The following is a description of a gene set: Reactome Pathway: Immune System This event has been computationally inferred from an event that has been demonstrated in another species.<p>The inference is based on the homology mapping from PANTHER. Briefly, reactions for which all involved PhysicalEntities (in input, output and catalyst) have a mapped orthologue/paralogue (for complexes at least 75% of components must have a mapping) are inferred to the other species. electronically inferred by orthology from the curated human pathway species: Mus musculus, and this is the list of marker genes: H2ac20, Dad1, Wsb1, H2-Q7, Trim32 (NCBI Gene Id 69807), Ifitm2, Crk, Cst3, Gan, Tnf, Mvp, Trim56, Ltb, Trim36, Ap2s1, Ifna16, Prkn, Defa36, Ly86, Pdzd11, C1ra (NCBI Gene Id 50909), Clcf1, Pag1, Tusc3, Ap1b1, Inppl1, H4c3, Nme2, Tlr6, Il16, Npm1, Atp6v0d1 (NCBI Gene Id 11972), Gpr84, Fcer1a, Fbxl8, C9, Pdap1, H2ac8, Mapk7, H2-M10.1, Faf2, Tlr1, Ezh2, Fbxo27, Neu1, Defb18, Traf3, Enpp4, Klrc2, H2ac4 (H2A clustered histone 4), Tab2 (NCBI Gene Id 68652), Nckipsd, Ulbp1, Ptk2, Asb16, Mapk8, Atp6v0a4, Il12b, Ptges2, Cdc23, Casp1, Galns, Actr2 (NCBI Gene Id 66713), H2-M9, Copb1, Lpo, Tubal3, Kifap3, Fbxl19, Pdcd1, Fkbp1a, Nf2, H3c15, Colec11, Itgax, Pianp, Rnf217, Rbsn, Il6, Leap2, Cd70, Lta, Crispld2, Rnf7, Eif4a1, Cd14, Tubb4b, Prkacb, Ppp2r5d, Smurf1, Cpped1, Nkiras1, Pik3c3, Ubac1, Sumo1, Gbp2, Casp9, Ear6, Atp6v1a, H2ac23, Ube3b, Lif, Sugt1 (SGT1, suppressor of G2 allele of SKP1 (S. cerevisiae)), Pja1, Kctd7, Tlr4, Serpinb3a, Defa39, Psg22, Vcp, Lonrf1, Tnfsf12 (tumor necrosis factor (ligand) superfamily, member 12), Chit1, Trim50, Psmd7, Ptpn2, Prkag3, Ap2b1, Rnf19a, Ormdl3, Ifngr2, Pdpk1 (3-phosphoinositide dependent protein kinase 1), Ppp2r5b, Aim2, Stt3a (STT3, subunit of the oligosaccharyltransferase complex, homolog A (S. cerevisiae)), Orm2, Csf1r, Ptpn6, Dync1li2, Pla2g2a, Fancc, Ear2, H2az2, Cdk13, Bpifa1, Defb19, Rnf6, Hcst, Tmem63a, Ube2e2, Ifna12, Lgmn, Faap100, Irak3, Fyn, Try10, Cmtm6, Bpifb6, C5ar1, Il6ra, Plau, Ifnl3, Il33, Defa30, Tnfrsf1a, Erap1, Smarca4, Asb17, Eppin, Rasgrp1, Sec24a, Tifa, Tlr8, Kctd6, Ifna14, Cct8, Socs2 (NCBI Gene Id 216233), Tuba1b, Defa20, Cfi, Frmpd3, Rab3a, Cntfr, Ube2g1, Cd209a, Oscar, Tab3, Ap1s1, Cdc34, Itga4, Cenpe, Lag3, 1600012H06Rik, Hp, C1qc, Il2, Dnase1l1, Psma7, Mmp8, Ifi205, Eef1a1, B3gnt3, Gdi2, Psmc3, Eda, H2-M2, Vtn, Svs3b, Cxcl1, Cenps, Actr10, Lamtor1, Arih1, Ufl1, Det1, Card9, Defa42, Psma5, Thop1, Nlrp3, H2-Ob (NCBI Gene Id 15002), Asb18, Psmb10, Ctsh, Cd81, Fabp5, Clec4a3, Fpr1, Klrk1 (killer cell lectin-like receptor subfamily K, member 1), Ppp2r5a, Itgb5, Il2rb, Slpi, Defb3, Ms4a2, H2bc22, Vps35l, Osbpl1a, Fgr, Il13ra1, Gbp5, Map2k4, Rasgrp3, S100b, Ifitm3, Mapk9, Tnfrsf18, Panx1, Sdc1, Ifi30, Atp6v1f, Grap2, Vat1, Ceacam2, Klkb1, Npc2, Csf2rb, Prkag1, Rbbp4, Psma1, Kpnb1, Fnta, H3f3a, Cd300ld4, Tubb6 (tubulin, beta 6 class V), Dctn1, Treml2, Tnfrsf17, Trem2, Ddost, Bcl2l1, Vhl, Sec24d, Cep290, Map2k3, Ear10, Adgre5, Nfam1, Btn1a1, Atp8a1, Tubb4a, Prg2, Kif5b, Cd55, H2-M10.6, Siglec1, Raet1e, Tmem30a, Itgb7, Cd300e (NCBI Gene Id 217306), Mapk12, Rab18, Orm1, Tnfrsf1b, Slc44a2, Il36a, Mib2, C1qa, Crlf1, Pgm2, Bpi, Tnfaip3, Grn, Herc3, Slc2a5, Dock2, Kif2c, Prg3, Dctn6, Vapa, Psma3, Tnfrsf13c, Nfkb1, Cd27, Casp3, Ifng, Irag2, Faap20, Cpn2, Ccnf, Atp6ap2, Rnf111, Prss2, Ppp3r1, Calr, Arhgap9, Cda, Ncf1, Il4, Sla, Socs3, Atp6v1e2, Ctsc, Kcmf1, H2ac22, Dtx4, Defa21, Anapc2, Casp8, Pglyrp3, Uba5 (NCBI Gene Id 66663, ubiquitin-like modifier activating enzyme 5), C4b, Hvcn1, Cd3g, Serpinb3c, Pld2, Hsp90b1, Defb25, Il9r, Ube2k, Ifna15, Asb5 (NCBI Gene Id 76294), Fzr1, C8a, Cdc42, Il1f10, Rchy1, Fbxl5, Mapk14, Fbxl15, Rela, Tyk2, Tnfsf15, Tirap, Jak3, Cul1 (cullin 1), Spop, Arpc4, Actr1a, Ube3d, Atp6v0c, Asb8, Gstp1, Reg3d, Pja2, Lcp2, Malt1, Slc11a1, Psma2, Adgrg3, Olfm4, Stim1, Tnfsf13, Nlrp4c, Pycard, Icam2 (NCBI Gene Id 15896), Defa17, Fancb, Cul7, Jup, Ctsf, Tlr2, Rictor, Fbxw4, Ceacam1, Il22 (interleukin 22), Erlec1, Kng2, Csnk2b, Tlr7, Ifna4, C5ar2, Lmo7, Il11, Tasl, Stk10, Fcna, Tnfsf14, Gsdmd, C3, Asb14, Ifna1, Ifnl2, Ube3c, Atp6v0e2, Arih2, Reg3g, Cd226, Siglecg, Sting1, Ampd3, Defa32, Fbxo9, Map3k3 (mitogen-activated protein kinase kinase kinase 3), C6, Mapk11, Rnf144b, Unc13d, Mapt, Flt3l, Arpc5, Vnn1, Lnx1, Cd28, H3c7, Ifngr1, Rbbp7, Klc4, Tnfrsf25, H4c12, Rab37, Ap1m1, Ifnlr1, Defb14, H4c6, Lamtor2, Trim69, Pstpip1, Defb21, Nos2, Glipr1, Ear1, H3c4, Il1rl1, Il1r2, Cant1, Psmd13, Irs2, Camk2b, Psmc5, Hexb, Tuba1a, Rnase6, Fbxl21, Ube2n, Treml1, Pde12, Trim11, Klrc1, Ahsg, Adam8, Tlr9, Pld3, Il2ra, Fbxo10, Rnf123, Cd36, Dok3, Arg1, Snca, Ilf2, Acaa1b, Cd3e, Rnase2a, Cpn1, Casp2 (NCBI Gene Id 12366), Gh, Cd68, Defa23 (defensin, alpha, 23), Il27ra, Masp1, Colec10, Lta4h, P4hb, Reg3b, Fbxo17, Eif4e3, Ifi211, Atp6v1g3, Ep300, Il21, F12, Ifnab, Stat5a, Irak1, Armc8, Hecw2 (NCBI Gene Id 329152), Pilra, Mmp25, Cd300ld5 (NCBI Gene Id 100043125), Slco4c1, Lrrc14, Rap2c, Tarbp2, F2, Tuba8, Lrr1, Pnp, Ccr6, Fgl2, Il20ra, Hrg, Tuba3b, H2-M10.2, H3c13, Dsg1a, Dusp7, Rac2, Ubb, Hebp2, Il36b, H2ac24, Igf2r, Rps27a, Ube2r2 (ubiquitin-conjugating enzyme E2R 2), Sec31a, Nlrx1, Fancg, Brwd1, H2ac10, Erp44, Tuba4a, Ticam2, Slamf7, Xrcc6, Siglece, Relb, Pik3ap1 (phosphoinositide-3-kinase adaptor protein 1), Masp2, H2-Oa, Btn2a2, Cnn2, Tyrobp, Defa34, Sftpd, Psme1, Fbxl16, Snap29, Ap1s3, Ckap4, Traip, Trem1, Sqstm1, Defa31 (NCBI Gene Id 13226), H2bc12, Asb12, Smurf2, H2bc13, Ppia, Arf1, Clec4n, Uba1 (ubiquitin-like modifier activating enzyme 1), Psen1, Cd300ld3, Il2rg, Il18rap, Tnfsf8, Optn, Defb48, Dynll1, Capn1, Cfp, Them4, Calm1, Arsa, Il34, Ms4a3, Shc1, Rnf213, H4c2, Il1a, Map3k8, Vrk3, Ctla4, Spsb2, Dynlt1a, Cd80, Lilra5, Prcp, Ost4, Col17a1, Fbxo30, Cotl1, Map2k7, Bri3, Nhlrc3, Igll1, Tnfrsf11b, Stx3, Tcirg1, Fbxo32, Bpifa2, Kif2b, Rigi, Rnaset2a, Mefv, Cd3d (CD3 antigen, delta polypeptide), Ube2s, Lbp, Btnl9, C1s2, C1qb (NCBI Gene Id 12260), Il10ra, Impdh2, Il11ra1, Il31, Trat1, Clec4d, Yes1, Defb42, Vamp8, Reg3a, Mapk13, Defa3, H2-M3, H4c9, Cntf, Jaml, Tnfrsf11a, Defa25, Rab7, Ilf3, Cyld, Klhl41, Ube2w, Psma6, Defb43, Defa26, H2bc7, B2m, Socs1, Lck, Defb36, Tnfrsf14, Nectin2, Defa37, Cyba, Psmb9, Ifna9, Ghdc, H2bc11, H3c10, Irf3, Asb9, Psmd6, Arel1, Mrc2, Defa38, Cd8b1, Defb1, Bpifb4, Ube2d1, Unc93b1, 2310033P09Rik, Tnfrsf4, Creg1, Ifitm1, Ppp2r1b, Anapc7, Hspa1l, Dnm2, Cbll1, Mavs, Ctsd, Fos, Siglecf, Il1r1, Slc27a2, Crtam, H3c1, Il18r1, Tap1, Rab9b, Crisp2, Serpinb3b, Il19, Atg7, Sos2, Tab1, Atp6v0e, Vav1, Wasf3, Mapk3, Lamp2 (NCBI Gene Id 16784), Kif20a (NCBI Gene Id 19348), Itgal, Cdc26, H3c3, Arl8a, Osmr, Trim39, Cd79a, H2ac19, Eif4a2, H2ac6, Pak3, Il27, Itk, Il9, Ctss, Nfkb2, Icos, Tec, Man2b1, Sh3glb2, Prdx4, Peli2, Il23r, Btbd1, Dapp1, Actr3, Anxa2, Icam4, Eef2, Cd177, Atp6v1d, Cstb, Psap, Kif26a, Ccnd1, Prkaca, Becn1, Rnf126, Rnf4, H3c11, Csk, Racgap1, Pik3r2, Cd300ld, H4c4, Oasl1 (2'-5' oligoadenylate synthetase-like 1, NCBI Gene Id 231655), Pnp2, Defb28, Tnfsf11, Anpep, P2rx7, H2ac1, Nlrc5, Cfd (complement factor D), Syk (spleen tyrosine kinase), Mcemp1, Alad, Defa28, Cd46, Gsn (gelsolin), H2bc8, Ppl, Rnf182, Fbxo31, Cyfip2, H3c8, Mre11a, A2m, Naprt, Mospd2, Pglyrp4, Il5, Fbxl14, Kpna1, Il31ra, Cd200r2, Il15, Osm, Il21r, Dtx3l, Itgb2, Defa43, H3c6 (NCBI Gene Id 319151), Il10, Pa2g4, Cdkn1b, Sec24b, Tmem258, Derl1, Clec4b2, Klhl13, Aldh3b1, Atp6v1g2, Rab10, Elane, H2-Q10, Psmb6, Cbl, Hmgb1, Hspa2, Chga, Kbtbd8, C8g, Defa24, H2bc1, Cd300lb, Psme2, Il20, Il3, Gzmm, Clec12a, Plaur, Trpc1, Kbtbd13, Ptprc (NCBI Gene Id 19264), Cct2, Arpc2, H2ac7, Cracr2a, H4c14, Ecsit, Mbl2, Ppm1b, Irf7, Pla2g6, H2bc15, Siah1a, Klrc3, Psmb5, Serping1, Dcaf1 (NCBI Gene Id 321006), H2bc9, Icosl, Il18bp, Psmc6, Defa41, Birc3, Fbxl4, H2bc27, Fbxl7, Irf9, Cxcr2, Il5ra, Nfkbie, Anapc10, Qpct, Clec4a4, Clec4g, Cd207, Pglyrp1, Klrb1a, H2ac12, H2ax, Ctsg, Mif, Defa35, Sptbn2, Stat4, H3c2, Hk3, Psg29, Dus2, Camp (cathelicidin antimicrobial peptide), Cd19, Myd88, Tubb2b, Apeh, Csf2, Klhl5, Tnfaip6, Kif3c, Kcnab2, Cd79b, Lat, Cxcr1, Clec4b1, Stx4a, Sh2b3, Anapc13, Pkm, Aldoa, Cr1l, Irf5, H2ac15, Hras, Fbxo40, Rab6a (NCBI Gene Id 19346), Ap2m1, Blnk, Rab5c, Svip, Fbxl3, Il4ra (interleukin 4 receptor, alpha), Sdcbp, Fance, Hectd3, Ncf2, Cdk4, C3ar1, Atp6v0a1, Txn1 (NCBI Gene Id 22166), H2ac11, C2, H4c18, Cystm1, Irs1, Ube2o (ubiquitin-conjugating enzyme E2O), Tspan14, Klrd1, Cd96, Epx, Rab44, Defb47, Dynlt1b, Dusp6, Ist1, Asb10, Rnase2b, Ifnar1, Xdh (NCBI Gene Id 22436), H2ac13, Hmox2, Cdk1, Ddx41, Tuba1c, Sel1l, Pik3cb, Psmb8, Tnfsf9, Unkl, Prtn3, Pigr, Ap2a1, Ifi204, Tnfsf18, Grb2, Cblb, Ube2c, Uba7, Ube2v1, Tap2 (transporter 2, ATP-binding cassette, sub-family B (MDR/TAP)), Hc, Tom1, Nfkbib, Glmn, Cenpx, Ptpn22, Clec4a2, Psmb4, H2bc3 (H2B clustered histone 3), Psmd1, H4c11, Trp53, Map3k14, Hectd2, Vamp2 (NCBI Gene Id 22318), Stx1a, Cd40lg, Hbb-bt, Il13ra2, Casp4, Flnb, Il23a, Ube2e3, Lrsam1, Plcg2 (NCBI Gene Id 234779), Klc3, Ube2e1, Psmd12, Stt3b, Tpp2, Fth1, Ifi44, Bpifb1, Trim9, Pfkl, Apob, Wasf1, Ager, Cd74, Prss3, Nfasc, Cap1, Tslp, Tarm1, H4c17, Atp6v1c2, Ebi3, Nfkbia, Fbxl13, Jun, Rps6ka5, Psma4, Arhgap45, Cd274, Icam5, Fadd, Ifnb1, Ctf1, Psmc4, Folr2, Stat5b, Derl3, Atp11b, Ctnnb1, Psmc2, Ly96, Il12a, Pdcd1lg2, Asb11, Il24, Klhl11 (NCBI Gene Id 217194), H4c8, Csf3, Map2k6, Art1, Pik3r5, Fbxw9, Fcnb, Btbd6, H4c1 (H4 clustered histone 1), Psmb7, Bcap31, Ikbkb, Fgg, Ptpn1, Psmc1 (protease (prosome, macropain) 26S subunit, ATPase 1), Ifna13